The following is a description of a gene set: from publication Hay SB, Ferchen K, Chetal K, Grimes HL, Salomonis N (PMID 30243574) Human Gene Set: HAY_BONE_MARROW_IMMATURE_NEUTROPHIL studied in species Homo sapiens, and this is the list of marker genes: NINJ1, NOTCH2, FCGR1BP, ZFP36L1, CPVL, RAC1, ASAH1, ZNF385A, MGAT1, ITM2B, HK2, PCBP1, ICAM1, DDX3X, CD4, TMEM70, IFNGR2, EVI2A, RIPK2, PFKFB3, DSE, ARF6, RIOK3, ZDHHC1, SECTM1, MARCO, NAMPT, VAMP3, RELT, SH2B3, USP3, CD300E (CD300e molecule), DUSP6, FUOM, NEAT1, CCR1, MYO9B, PLEKHB2, KLF10, LUCAT1, RNF19B, HCAR3, RAB20, ABCA1, LACTB, VEGFA, IFI6, RTN1, ATP2B1, IER3, FOXO3, NPC2, ARRDC3, DDIT3, BCL3, LCP2, EVI2B, IFI30, IL13RA1, BIRC2, MAPK6, METRNL, SLC43A2, GRB2, CLEC4A, CRTAP (NCBI Gene Id 253263), MAP3K8, ZEB2, CPEB4, PTP4A2, NAMPT-AS1, HMOX1, CIMAP1B, PELI1, SLC16A6, GRINA, NLRP3, CDC42, PLSCR1, CTNNB1, ZFYVE16, APOBEC3A, PICALM, KDM6B, GAB2, SHTN1, B3GNT5, ICOSLG, PLIN2, PHLDA2, CLEC7A (NCBI Gene Id 64581), CCL3L3, RHOA, HPSE, NFKBIA, LGALS3, CTSB, TXNIP, CEBPB, HAPSTR1, HIF1A, ATP6V1F (NCBI Gene Id 9296), BHLHE40, CARD19, NUMB, PPT1, PFDN5, ID1 (inhibitor of DNA binding 1), BACH1, FCGR1A, C15orf39, MAP3K2, CTSS, TLE3, RIT1, GABARAPL1, ZFHX3, MAFB, FCGRT, EP300, FTL, SEC11A, FAM91A1, SLC6A6, UBE2D3, GLUL, CEP170 (NCBI Gene Id 9859), PRKAG2-AS1, PTP4A1 (NCBI Gene Id 7803), KLF11, IER5L, BCL2L11, IFITM10, JARID2, AHR, C9orf72, ATP2B1-AS1, RNF141 (NCBI Gene Id 50862), UBA52, IER5, HSD17B11, GPX4, CD86, SLC8A1, TRMT1, EMP3, CEBPD, THBD, RAB1A, G0S2, FCGR2A, CYRIA (CYFIP related Rac1 interactor A), DPYSL2, BCL2A1, PRKAG2, UPP1, IRF2BP2, HBEGF, GNA13, MIR22HG, VMP1, SUSD6, CDKN1A, PID1, RBPJ (recombination signal binding protein for immunoglobulin kappa J region), ATP6V1G1, SERTAD2, BNIP3L, GPCPD1, PEA15, TMEM127, SAT2, ARRDC4, IL10RA, UBE2R2, C15orf48, RAP2B, SH3BP2, LGALS2, RNF145, IL1B, SLC30A1, PRCP, TNFAIP2, LIPA (lipase A, lysosomal acid type), ARL4A, TMEM219 (transmembrane protein 219), CRIP1, H3-3B, SGK1, ARHGAP27, EPB41L3 (NCBI Gene Id 8730), USP12, RHOQ, PCBP2